Given this list of marker genes Diablo, Gng13, Ap2a2, Msn, Acp1, Pgm5, Samd10, Ppp3ca, Esyt2, Ryr3, Gna12, Gna15, Gnai3, Gnb1, Cdk16, Gng2, Spta1, Plekha4, Fer, Dsg1a, Kcnab2, Kras, Ldlrap1, Ptpn3, Rasa3, Gnat2, Stac, Iqce, Esyt3, Ppp1r9b (protein phosphatase 1, regulatory subunit 9B), Epn3, Htra2, Samd12, Syap1, Nphs2, Tirap, Gnb5, Rgs8, Traf6, Gna11, Pten, Gnat1, Gnaq, Cdh1, Fes, S100a6, Dsg1c, G6pd2, Myh9, Gng3, Stac3, Dlg1, Rgs1, Prmt8, Jak2, Traf3, Kit, Gnb2, Fgfr3, Fermt2, Frmd6, Stac2, Dst, Syt6, Ap2s1, Tgm3, Gng11, Dnaja3, Gng4, Akap5, Rasgrp4, Myd88, Rnf31 (NCBI Gene Id 85306), Kcnip1, Litaf, Gnai1, Dtna, Myzap, Slc4a1, Osbpl2, Gng7 (NCBI Gene Id 14708), Jak3, Chmp7, Cabp1, Ap2b1, Gnao1, Epb41, Map2k2, Atp2a2, Gng12, Cnr2, Shroom4, Gng14, Pkp4, C2cd2l, Gna14, Gnaz, Ptp4a1, Ap2m1 (adaptor-related protein complex 2, mu 1 subunit), Chmp4b, Ptpn7, Gnas, Gphn, Gm2a, Alox15, Gng10, Ryr2, Mtss1, Gng8, Nlrp10, Rab21, Gnal, Jak1, Lyn, Kcnab1, Th, Ajap1, Gem, Cd2, Gngt1, Aspscr1, Traf2, Gna13, Efcab7, Ptpn22, Gnat3, Traf5, Birc2, Snx5, Drd4, Farp1, Cyld, Rhoa, Npcd, Ank1, Jup, Gnb3, Loricrin, Mtss2, Socs3, Gnb4, Mien1, Snx18, Ncf1, Gng5, Iqgap1, Mapt, Racgap1 (NCBI Gene Id 26934), Cyth1, Hck, Ap2a1, G6pdx, Ank2, Atp2b1, Gng5c (NCBI Gene Id 636193), Ryr1, Ptpn4, Chmp4c, Ikbkb, Atp2c2, Mcf2l, Myh10, Rgs2, Gngt2, Chuk, Ntsr1, Ptprc, Gnai2, Dsg1b, here is a description of the gene set: The leaflet the plasma membrane that faces the cytoplasm and any proteins embedded or anchored in it or attached to its surface. studied in species Mus musculus Mouse Gene Set: GOCC_CYTOPLASMIC_SIDE_OF_PLASMA_MEMBRANE